The following is a description of a gene set: species: Mus musculus Genes predicted to be targets of miRBase v22 microRNA mmu_miR_700_5p in miRDB v6.0 with MirTarget v4 prediction scores > 80 (high confidence targets). from publication Chen Y, Wang X (PMID 31504780) Mouse Gene Set: MIR_700_5P, and this is the list of marker genes: Amfr, Raet1e, Galc, Igf2bp3, Acsl1, Rnf157, Cep135, Mapk7, Dyrk2 (NCBI Gene Id 69181), Nek4, Wtap, Zeb2, Rnf169 (NCBI Gene Id 73007), Rbm22, Cep41, Atrx, Jag1, Yod1, Ntsr1, Tead1, Gpat3, Dpep1, Rras2, Zbtb5, Rin2, Coro2b, Slc16a1, Nap1l1, Arl13a, Gnas, Mfsd14a, Acaca, Plod2, Mgat4a, Fam107b, Cdyl2, Prdm1, Mosmo, Ago1, Rac1, Kdm1b, Sass6, Selenon, Eif3j2, Ntn5, Usp37, Kat6a, Rps27l, Bcl11b, Ro60, Ccdc3, Pakap, Ube2q2l, Rapgef2, Rimklb, Myo9b, Zc3h10, Usf3, Apbb2, Kmt2a, Ccn4, Cpsf6, Zbtb10, Dchs1, Mylip, Drd1, Twnk, Sema4a, Ptp4a1, Plk3, Per2, Sdk1, Nectin3, Csgalnact2 (NCBI Gene Id 78752), Ctbp2, Syne1, Itgal, Fyco1, Efnb2, Shh (sonic hedgehog), Wasf1, Entpd7, Tgm2, Zfand3, Agpat3, Spred2, Vgll3, Rap2c, Atad1, Osbpl5, Rhbdl1, Opa3, Fanci, Slc18a2, Cecr2, Sox9, Rhoj, Tjp1, 1700025G04Rik, Zxdb, Zbtb11, Lancl3, Matr3, Als2, Med26, Raet1d, Atp1b1 (ATPase, Na+/K+ transporting, beta 1 polypeptide), Slc35a1, Rsbn1l, Mtmr6, Tmem94 (transmembrane protein 94), Bcan, Slc5a9, Cfl2, Wdtc1, Jarid2, Klf11, Setd7, Mras, Fsd1, Mkrn3, Fgf12, Atg3, Tsc22d2, Reg3b, Ssbp1, Naa15, Zfp764, Gtf2e1, Ncor2, Smg1, Arhgap32, Fscn1, Il1rap, Htr2c (5-hydroxytryptamine (serotonin) receptor 2C), Pag1, Inpp5f, Gabbr2, Bcl11a (BCL11 transcription factor A)